Given this list of marker genes Klk5, Pgc, Ivl, Il17a, Klk7, Il17f, Ppl, Nod2, Evpl, here is a description of the gene set: Any process that modulates the frequency, rate, or extent of antimicrobial peptide production. Mouse Gene Set: GOBP_REGULATION_OF_ANTIMICROBIAL_PEPTIDE_PRODUCTION species: Mus musculus